The following is a description of a gene set: Human Gene Set: GOCC_PLATELET_DENSE_TUBULAR_NETWORK_MEMBRANE studied in species Homo sapiens The lipid bilayer surrounding the platelet dense tubular network., and this is the list of marker genes: EHD1, ITPR1, ATP2A1, ITPR2, DMTN, ITPR3, ATP2A2, ATP2A3, IRAG1